The following is a description of a gene set: studied in species Homo sapiens Human Gene Set: GOBP_AMINOGLYCAN_CATABOLIC_PROCESS The chemical reactions and pathways resulting in the breakdown of aminoglycans, any polymer containing amino groups that consists of more than about 10 monosaccharide residues joined to each other by glycosidic linkages., and this is the list of marker genes: CHIT1, LYG1, PGLYRP1, CTBS, STAB2, TGFB1, CHI3L1, LYVE1, CD44, CEMIP2, CEMIP (NCBI Gene Id 57214), SGSH, HYAL3, HMMR, PGLYRP4, GUSB, HYAL1, HYAL2, HEXA, IDUA, SPAM1, IDS, HEXB, PGLYRP3, FGF2, CHIA, OVGP1, PGLYRP2, HYAL4, CHI3L2, GNS, LYG2